Given this list of marker genes CSF2RA, TK2, CSF2RB, DOCK11, GAA, TRMU, GCSH, ACTA1, MT-TE (mitochondrially encoded tRNA-Glu (GAA/G)), USP18, TSEN54, DPYD, MTM1, NDUFAF8, SMPD1, AHDC1, HPDL, TEFM, MYH11, PRPS1, ARSL, ALAD, SLC25A46, TFG, TBK1, SLC52A3, PRIM1, TRAF3, IGHMBP2, UNC93B1, HMGCR, POLR1B (NCBI Gene Id 88998), SCO2, GNPTAB, TLR3, BCHE, TBCD, TICAM1, here is a description of the gene set: Respiratory failure requiring assisted ventilation studied in species Homo sapiens A state of respiratory distress that requires a life saving intervention in the form of gaining airway access and instituting positive pressure ventilation. Human Gene Set: HP_RESPIRATORY_FAILURE_REQUIRING_ASSISTED_VENTILATION